The following is a description of a gene set: from publication Chen Y, Wang X (PMID 31504780) species: Homo sapiens Genes predicted to be targets of miRBase v22 microRNA hsa-miR-3936 in miRDB v6.0 with MirTarget v4 prediction scores > 80 (high confidence targets). Human Gene Set: MIR3936, and this is the list of marker genes: DGKI, APC, PTPN4, SNRK, FBXW4, IFT80, MS4A6A (NCBI Gene Id 64231), HYCC2, FBXO42, AZIN1, JAGN1, TNIK, SLC35A2, TSPAN8, FGD4, CRH, CFHR5, VBP1, NDUFA2, HELZ, BCL2L1, TMUB2, TPRX1, FMO1, ZFHX3, UFM1, ZMYM2, PFN1, ZBTB20, LINC03106, OR2A4, NMNAT1, PPP1R11, ESR1, TCF20